The following is a description of a gene set: species: Homo sapiens Human Gene Set: GOBP_ENTRAINMENT_OF_CIRCADIAN_CLOCK The synchronization of a circadian rhythm to environmental time cues such as light., and this is the list of marker genes: BMAL2, RBM4 (RNA binding motif protein 4), PPP1CB, CRY1, SOX14, ID2, OPN5, FBXL3, NR2F6, SIK1, CRTC1, PHLPP1, PER3, PER2, PPP1CA, MTA1, GNA11, FBXL21P, ATOH7, CRY2, PML, BHLHE40, TP53, PDE6B, PPP1CC, USP2, RBM4B, GNAQ, PER1